Given this list of marker genes Me3, Akr1b8, Gmds, Hsd17b1, Akr1c21, here is a description of the gene set: species: Mus musculus Binding to the oxidized form, NADP+, of nicotinamide-adenine dinucleotide phosphate, a coenzyme involved in many redox and biosynthetic reactions. Mouse Gene Set: GOMF_NADPPLUS_BINDING